The following is a description of a gene set: species: Homo sapiens Vitamins Human Gene Set: REACTOME_VITAMINS, and this is the list of marker genes: CYP26B1, CYP26A1, CYP2R1, CYP27B1 (NCBI Gene Id 5135), CYP26C1, CYP24A1